The following is a description of a gene set: Genes up-regulated in comparison of lymph node regulatory T cells versus thymus regulatory T cells. from publication Feuerer M, Herrero L, Cipolletta D, Naaz A, Wong J, Nayer A, Lee J, Goldfine AB, Benoist C, Shoelson S, Mathis D (PMID 19633656) species: Homo sapiens Comparisons of global gene-expression profiles revealed a greater distinction between CD4+ Treg cells and CD4+ conventional (Tconv) T cells residing in abdominal (epidydimal) fat versus in more standard locations such as the spleen, thymus and LN. Human Gene Set: GSE7852_LN_VS_THYMUS_TREG_UP, and this is the list of marker genes: FGF13, PARP3, CD86, DUBR, WIPF2, CD72, ABCC4, ATF7IP, PSEN2, PGPEP1L, ANTXR2, PEAR1, FASLG, DOK1, FCMR, SLC35A5, HNRNPLL, AKNA, TNFRSF1A, IRF4, SUPT20H, TRIM68, RPS6KA2, PRKCE, CDCP1, POU6F1, FAM210B, TMEM63A, ARHGAP31, ANKLE2, NMNAT3, RNPEP, MAN1C1, ST6GALNAC4, PTPRJ, ABTB3, KCTD2, CXCL3, TMEM154, CST7, HLA-B, PLXNC1, CPE, RAB43, NFIA, ARRB1, GALNT10, RUNDC3B (RUN domain containing 3B), KHDC1L, TTN, TMBIM1, EI24, NDST1, LPXN, SPN, ADGRD1, GBP4, RSAD1, PRKCA, PGGHG, ATG4C, TBC1D14, TIRAP, TBC1D30, QPRT, CREB3L2, KIAA0930, PIGK, PDCD11, PACS1, CASP4, PTGER4, AGO3, FOXRED2, RAB6B, OXR1, ACOT11, ACAP1, PHLPP2, TMEM209, GNA11, MFF, LRIG1, HEXA, IFIT1, SEPTIN8, ART3, ITGA6, H3C7, KLHL12, ANKH, DAPP1, PTGER2, CBX7, MIDEAS, ATP6V1D, ABHD14B, WSCD2, RBM43, TNF, CPM, GPR68, RNF123, SLC12A7, DDX3Y, FLNB, HGSNAT, SYNPO, USP36, UNK, CYP4V2, FBXO32, SH2D4B, PRXL2C, GUCY1B1, ETV1, BMP2K, CKB, H2AB2, SLC28A2 (solute carrier family 28 member 2), CYP2R1 (cytochrome P450 family 2 subfamily R member 1), TWSG1, UBASH3B, CRBN, NR1D2, FOXN3, OSBPL7, ABCB1, NR3C2, GPR15, BRF2, PDE2A, D2HGDH, TANC1, TDP2, SCD, XDH, MARVELD2, FMO5, KIAA0232, CCNG1, GBP2, GIMAP7, RCCD1, NT5E, KDM5D, TASP1, ARSB, SLC15A2, LINC00511, SHE, DMD, MS4A1, HOPX, FGD6, GNAQ, KIF13A, TPD52, SLC24A3, SNX9, PRG4, NLRC5, TMEM175, NUAK2, REC8, ADCY7 (adenylate cyclase 7), HVCN1, BANK1, ARHGEF12, MAT2A, LPIN1, CASP1, MTMR7, HLA-DQA1, ZNF131, PLCL1, TTC7A, JADE2, SLC2A3, KIF5C, ZNF180, SRGN, MAP3K7, SEC16B, HLA-E, IRAK3, PISD, LAX1, GPM6B, BCOR (NCBI Gene Id 57686), BCLAF1, NUDT19, CPQ, USP40, ARNT2, LCLAT1, IPCEF1, MAP7, MYH11, PLPP1